Given this list of marker genes HNF1B, PDGFRB (platelet derived growth factor receptor beta), SLIT2, ITGA3, MAGI2, FOXD1, PDGFB, SHH, ILK, GDNF, LMX1B, FOXC1, FOXC2, ROBO2, PAX2, NPHS1, HOXA11, LAMB2, HOXD11, ITGB1, ITGA8, NCK1, WT1, MAFB, FGF8 (fibroblast growth factor 8), TCF21, LHX1, FGFR2, SIX1, ETV4, NOTCH2, VEGFA, KIRREL1 (NCBI Gene Id 55243), NPHS2, EMX2, KDR, CD2AP, RET, EYA1, CXCR4, NCK2, CXCL12, CTNNB1, WNT4, GLI3, CD36, here is a description of the gene set: Genes controlling nephrogenesis studied in species Homo sapiens Human Gene Set: WP_GENES_CONTROLLING_NEPHROGENESIS